Given this list of marker genes Nos1, Ryr2, Slc9a1, Slc8a1, Myl2, here is a description of the gene set: Any process that increases the force of heart muscle contraction. species: Mus musculus Mouse Gene Set: GOBP_POSITIVE_REGULATION_OF_THE_FORCE_OF_HEART_CONTRACTION